Given this list of marker genes SNCA (NCBI Gene Id 6622), TOR1A, PARK7, DRD4, DRD2, PRKN, SLC6A2, SLC6A3, DRD3 (dopamine receptor D3), GDNF, DRD1, RAB3B, here is a description of the gene set: Human Gene Set: GOBP_CATECHOLAMINE_UPTAKE_INVOLVED_IN_SYNAPTIC_TRANSMISSION studied in species Homo sapiens The uptake of catecholamine neurotransmitters by neurons or glial cells. This process leads to inactivation and recycling of neurotransmitters.